Given this list of marker genes TRIM21, DNAJB12, CAMLG, OAZ2, RNF149, TGFB1I1, ADAMTS12, SOCS7, AGAP2, UBE2D2, DERL2, APP, MAP1A, FBXO4, KLHL2, ASB1, COP1, HYAL4, RSPRY1, WFS1, CDK2, SEC22B, DESI1, PRSS16, SF3B3, RNF7, DDIT3, SIRT1, AQP11, MIR128-1, RNF144A, SOX17, ATXN3L (ataxin 3 like), NRDC, WDR26, BCAS2, KCNE2, L3MBTL3, CHMP4A, SH3RF2, STX5, TLK2, ARIH1, UBR1 (ubiquitin protein ligase E3 component n-recognin 1), TMEM132A, PSMB6, USP25, ANAPC2, ERLEC1, PRAME, HGS, PSMB9, PRAMEF10 (PRAME family member 10), UBAP1, GZMA, VPS11, FURIN, XPO1, CAPN2, UBE2K, FBXW11, FBXL13, SERPINB12, IL33, RPS27A, PISD, PSMB4, NOTUM, PRAMEF22, RLIM, SPOPL, RNF139, HERC6, FLNA, ELANE, PAQR3, GRN, VPS36, PRAMEF5, ZFAND2B, CLN5, RNF20, EEF1A2, KLHL42, KEAP1, KLHL24, PSMD3, UFL1, PLAA, SNX33, UBE2S, UBE2C, ANKIB1, IRGQ, UBE3A, FBXL14, SLC6A7, FBXO38, TRIM38, CTSO, CUL1, VPS35, KLHL12, WNT1, TRIM72, PSME1, TMEM199, ANAPC7, CHMP6, STT3B, DCAF12, TIMP3, MTA1, PSMD14, ECRG4, TBX21, TRIM45, IVNS1ABP, KLHL23, USP14, HECTD3, SNX5, ADAM9, FBXO22, SKP1, SIAH3, LATS1, DDA1, AXIN2, CALR, CCDC47, CTSW, ZNF268, DENND3, CSNK2A3, GSK3B, RPS7, PIN1, AREL1, ASCC3, KLHL5, CELA1, TREM2, AMER1, TOLLIP, CDC26, TMUB2, ANXA2, RILP, FBXL20, F8A2, GIPC1, KLHL11, TMTC3, IL17RA, TP53INP2, KLHL35, PRAMEF19, KLF1, CELA2A, NOTCH1, CALR3 (calreticulin 3), MAGEF1, CUL4A, OGA, ISG15, PSMB2, FBXO24, BAG5, PSMA8, RNF41, CDC27, PSMA4, TBL1XR1, UBE3B (NCBI Gene Id 89910), ASB2, PSMD9, CTSH, NFE2L2, NEMF, KCTD5, STYX, OAZ3, RNF167, F8A3, ZFAND2A, TRIM24, PANO1, ANAPC4, UBQLN3, PTEN, ARMC8, UBE2L6, PSMA1, KLHL25, PPP1R11, FBXO8, SYVN1, ZNRF3, BTK, RNF175, GGA1, ADAM10, NQO1, FBXL5, TRAF2, PRAMEF26, DPP7, TMEM168, USP8, HECW1, HSP90AA1, PSMC6, NELL1, CASP8, UBE4A, PSMC2, NSFL1C, SMURF2, SIRT6, SPG11 (NCBI Gene Id 80208), RPL11, FBXL2, ZNRF4, TOPORS, CDC34, APC, CBLB, LYPLA2, PMAIP1, CUL7, BBS7, LGMN, RNF114, ATRAID, RNF13, DET1, RNF5, CANX, KBTBD7, PSME2, FBXL19, CPA1, LYPLA1, WAC, UBE2J1, TRIP4, LAPTM5, NDFIP1, PELI1, CRBN, PRAMEF33, UBE2I, RNF43, RNF144B, GABARAP, UBA7, IKBKG, CLOCK, FBXL15, CBLC, CHMP4BP1, KLHL3, BAG3, PJA1, F8A1, MTOR, CPA2 (carboxypeptidase A2), JKAMP (JNK1/MAPK8 associated membrane protein), ASB11, UBXN7, RC3H2, ENC1, TMEM259, TMX1, KLHL7, PRKN, CDC23, KBTBD12, RNF14, PSMA6, FBXO10, PCYOX1, APOC2, TF, RNF216, WWTR1, KCTD13, RHBDD1, TRIM26, TRIM3, CTSS, TSG101, GID8 (NCBI Gene Id 54994), UBR5, RNF6 (NCBI Gene Id 6049), SH3RF3, DNAJC3, RNF4, TRIM32, UBE2A, RELA, CAV3, PBK, NPLOC4, VPS37A, ANAPC10, TNFAIP3, SHARPIN, VHL, SOCS6, EPHA4, IER3, N4BP1, UBE2U, FBXL4, PCNP, DAB2IP, FBXO27, PABPN1L, RAB7A, UBA6, ANAPC5, VPS28, NEDD4L, RNF217, CD2AP, TBL1X, FMN2, IDE, ATP5IF1, ROCK1 (NCBI Gene Id 6093), NEDD8, SGSM3, PSMD11, SH3RF1, HECW2 (HECT, C2 and WW domain containing E3 ubiquitin protein ligase 2), PITHD1, KCTD2, NKD2, TRIM2, HSPA1B, EGFR, RNF34, TOM1L1, CHMP3, HYAL1, KLHL30, OTUD7A, UBE2L5, NOP53, CTRL, DAOA, MAD2L2, RPGR, CHFR, RCN3, MMP20, LPCAT1, UBQLNL, MGAT3, USP44, ARRDC1, ST14, PTPN3, ADAMTS4, HGSNAT, SNX3, RBX1 (ring-box 1), GPX1, PRAMEF13, WNT10B, CHMP1A, UBR7, VPS4A, AMN1, AGAP3, PACSIN3, CST3, RNF145, ADGRB1, FBXW7 (F-box and WD repeat domain containing 7), TRAF4, UBA1, CCAR1, SPSB1, MAN1C1, TRIB3, ANAPC1, CTSF, FMR1, SEL1L2, GZMB, CHEK2, HSPA1A, ANAPC13, USP17L6P, PPT1, CHMP2B, RCHY1, RNF40, SIAH1, RNF168, GCLC, APPBP2, HSPA5, TCIRG1, PDLIM2, MYCBP2, NGLY1, UBXN10, PKD1, CD81, BRSK2, CTNNB1, EXT1, TIPARP, CST7 (cystatin F), GNS, ZNF418, FEM1A, EGF, YOD1, PRAMEF1 (PRAME family member 1), ARRB2, ATG7, USP33, SIAH2, TRIM71, UFSP2, KBTBD2, HAMP, USP17L24, ARIH2, PSMF1, SGTA, PRKCG, HUWE1, PPP2R5C, UBQLN4, AZIN1, SMAD4, FBXL16, FBXO6, PSMD1 (proteasome 26S subunit, non-ATPase 1), ASB9, HM13, RNF126, ODC1, FBXL3, SNRNP70, UBD, RNFT1 (ring finger protein, transmembrane 1), NDUFA13, GSK3A, CDC20 (NCBI Gene Id 991), GPC3, PRAMEF15, CLU, PRAMEF8, EIF3H, MMP3, UBE2L3, LRRC75A, MVB12A, KAT5 (lysine acetyltransferase 5), RHBDD2 (NCBI Gene Id 57414), FBXL22, TNFRSF1B, PSMC5, TRAF7, ELOB, HSPA8, IL1B, CLPX, NHLRC3, ATE1, LAMP3, CBL, TMEM9, KCTD21, ANKZF1, EEF1A1, ABCA2, TAF1, CCIN, ADRM1, NUPR1, FBXO11, KLHL4, SPSB3, LRP1, TMEM129, FBXO31, SH3D19, MARCHF2, PTPN23, USP38, UBB, CENATAC, PRPF19, ZYG11B, HERC2, FBXO17, TNFSF12, SMURF1 (SMAD specific E3 ubiquitin protein ligase 1), MMP12, TRIM31, DCAF11, FBXL17, UFD1, ASB5, CSNK2A2, SNX1, HSP90AB1, CDK5RAP3, TSPAN15, MAD2L1, USP19, BAG2, UHRF1, OAZ1, HDAC6, SLC6A17, PSMD7, KLHL40, PARK7, UBR4, FBXW4, KLHL18, LDLR, CDC20B, TMEM67, GBA1 (glucosylceramidase beta 1), C4BPA, PSME3IP1, TRIM28, AMBP, FOXO1, RBBP6, CSNK1D, UBE2D1, HERC4, CPN1, GLMN, CMA1, CHMP4B, CUL2, UBXN11, UBR2, IDUA, WWP2, GRIN2C, MDM2, UBA52, LONRF2, SKP2, CSNK2B, ANAPC15, OTUD7B, SHH, AGTPBP1, LNX1, PABIR1, UMOD, MAN1B1, RNF130, SIRT2, STAM2, RNF146, ATF6, DERL3, KLHL38, CTSD, VCP, CCNF, PSMD6, KLHL22, RNF170, GUSB, CHMP5, FBXO9, SEM1, SPATA18, AP5Z1, VPS37B, PRAMEF17 (NCBI Gene Id 649345), CAV1, RDX, CUL5, BNIP3 (NCBI Gene Id 664), USP7, DMAC2, KLHL8, AFG2B, ABHD10, RNFT2, MIDN, TRIM40, KLHL29, PRAMEF4, APC2, KCTD10, DVL1, USP28, HERPUD1, USP13, TOR1A, TRIB1, ZDHHC2, MYLIP, UBXN2B, RNF187, FYN, AMFR, CYP51A1, EDEM2, KLHDC3, ERCC8, HERC3, TNF, ADAM8, RNF121, LONP1, CUL3 (NCBI Gene Id 8452), UBE2B, RNF11, TRIM9, CASP7, ARMC5, CDKN1B, UBE2J2, FAM83D, CLGN, TRPC4AP, PPP2CB, SLC17A9, UBXN1, PSMB7, PJA2, LIAT1, FBXL7, PSMD13, PCBP2, KCTD6, INS, VPS13A, TIMP2, RHOBTB3, MIB1, PYHIN1, PDCL3, PSMA3, LAMP2, ZRANB1, AURKA, ABHD17B, UBXN8, CLPP, DDI2, USP5, PSMB11, MTM1, FBXW5, DCST1, VIP, UBE3D, SORL1, CTSA (NCBI Gene Id 5476), CCDC115, LRIG2, PSME3, FBXO7, UBE2N, PSMB1, VPS4B, ADAMTS7, UBE2H (ubiquitin conjugating enzyme E2 H), HACE1, SNX12, UBE2Z, LTN1, CBFA2T3, MAN1A2, SMAD7, PRAMEF6, PCSK9, USP9X, HERC5, CTSC, PDCD6IP, FEM1C, HEXA, ATG5, PHF20L1, LRP2, UTP25, CDKN2A, RGMA, LONP2, PEX12, CEACAM1, RNF150, SMAD3, AZIN2, HSPBP1, ACR, OPHN1, UBXN6, DISC1, CNOT4, PSMB5, NUDT15, PSMA5, UBE3C, UBE2D4, KLHL28, ANAPC11, GAN, TRIM39, ATP13A2, UBE2E1, NR1D1, ELOC, MAGEA2B, IL10, RNF166, SGSH (N-sulfoglucosamine sulfohydrolase), MARCHF7, DEDD, TTC3, MARCHF6, RNF186, RNF8, PSMD8, PGPEP1, PSMD4, CLN8, PRICKLE1, SMARCC1, KLHL1, VPS37D, ANKRD9, RMND5A, ZNF598, BAG6, NDFIP2, PSMB8, RPL23, SUMO1, FBXO48, TMEM126A, BCAP31, XBP1, MAPK9, HPSE (NCBI Gene Id 10855), MDM4, UBR3, RNF133, ABHD17C, PCYOX1L, OSBPL7, CHMP1B, PIAS1, OS9, UBE2G2, MAGEA2 (NCBI Gene Id 83160), UBL7, NCCRP1, KLHL15, TMUB1 (NCBI Gene Id 83590), EDEM1, FAU, SDF2L1, HTRA2, RNF111, TAF9, TIMP1, VGLL4, FAF1, PRAMEF25, PSMA2, ARHGAP5-AS1, GPLD1, CTSZ, TRIM25, WNT5A, MAEA, DAB2, UBE2R2, BNIP3L, PML, DNAJC10, VPS37C, MSN (NCBI Gene Id 4478), DDB1, SUMO2, ADAMTS13, PSMD10, TPP1, MAGEC2 (NCBI Gene Id 51438), ADRA2A, RIPK1, KLHDC10 (NCBI Gene Id 23008), PRAMEF14, USE1, ZNRF1, APOB, CDH1, AGBL4, NEU2, HFE, MVB12B, UBAP1L, WDR77, STAM, UBC, UBE2D3, DTX3L, PRAMEF18, TMF1, OXA1L, PSMB10, BMAL1, RNF122, IPP, FAF2, RAB12, LAPTM4B (NCBI Gene Id 55353), RNF10, RACK1, FBXW8, DCAF13, PSMD2 (NCBI Gene Id 5708), PSMB3, FAM8A1, ALAD, TRIM58, NHLRC1, RGP1, CUL4B, DTX4, LRRK2, AMBRA1, MANBA, UBXN2A, ZSWIM8 (NCBI Gene Id 23053), ABHD17A, COMMD1, PRAMEF20, AKIRIN2, SOCS4, C4BPB, IFNG, SPSB2, DDI1, KBTBD6, UBQLN2 (NCBI Gene Id 29978), TRIM13, PRAMEF9, PTK2, SVIP, DERL1, SOCS5, OGT, NFE2L1, DNAJB2, CACUL1, RPL5, CSNK1A1, KLHL17, ECSCR, RAD23A, WDR81, CHMP2A, ARAF, PHB1, LRSAM1, KLHL20, YME1L1, PLK3, STUB1, SELENOS, KLHL10, RYBP, PRAMEF2, PRAMEF11, BAP1, ATM, CCDC22, NKD1, RHBDF1, SQSTM1, PSMC3, RNF180, EPG5, SNX9, RBCK1, NEURL3, PTK2B, WWP1, TMEM106B, RNF123, FBXO39, COPS3, HSP90B1, NEDD4, SENP1, RNF125, PINK1, PRKACA, ZER1, PSMD12, RNF215, DACT1, CDC16, ECPAS, UBL4A, ERLIN1, KLHL41, NEU4, SPSB4, CLN6, UCHL3, UBE2G1, SEL1L, TSPAN5, UBE2W, TRIB2 (NCBI Gene Id 28951), EZR, EPM2A, TIMP4 (TIMP metallopeptidase inhibitor 4), PLK2, SOCS2, GGA3, CHMP7, HIPK2, CREBRF, KCMF1, DDRGK1, ZNRF2, OMA1, NAGLU, CAPN3, AKT1, GFAP, MKRN2, PRAMEF27, FBXO46, SAYSD1, PRMT6, FBXL6, HEXB, QRICH2, SOX9 (NCBI Gene Id 6662), GID4, BRINP1, UBQLN1, RNF148, RNF185, APOE, TRIP12, KLHL6, PRAMEF7, WDR91, HMGCR, UBXN4, IRAK3, NTAN1 (N-terminal asparagine amidase), USP26, RNF213, CASP3, MFSD8, FBXO44, FOXF2, RFPL1 (ret finger protein like 1), PEX10, BFAR, ITCH, ARK2N, SUFU, SPOP, SH3BGRL, AUP1, PRAMEF12, VPS25, DNAJB9, FBXO2 (F-box protein 2), EFNA1, ARRB1, KBTBD8, IDS, DCAF1, RNF25, RNF128, ATXN3, FHIT, KCTD17, PLK1, SERPINE2, FBXL18, FAP, PSEN1, CUL9, ASCC2, FBXL12, BARD1, RHBDD3, BIRC2, CHMP4C, CSNK2A1, GLB1, CTSK, TNFAIP1, PSMA7, NUB1, EDEM3, RNF19B, FOXRED2, RNF103, FEM1B, PSMC4, IFT80 (intraflagellar transport 80), MMP14, CTSL, GRIN2A, ZMPSTE24, CSNK1E, CTSV, PSME4, RC3H1, RNF19A, TTC36, KLHDC2, BTRC (beta-transducin repeat containing E3 ubiquitin protein ligase), UCHL1, SNF8, TRIM67, GET4, MALT1, GABARAPL2, AXIN1, EGLN2 (egl-9 family hypoxia inducible factor 2), FZR1, FBXO21, HECTD1, DTL, UBAC2, MIR181B1, AFG1L, CLN3, KBTBD3, MAN1A1, DNAAF4, GNA12, KLHDC1, ERLIN2, CCAR2, FBXO45, PPP2R3A, NOS2, CEBPA, RNF26, LNPEP, IFI27, FBXO3, TSPAN17, UBE4B, MME, AFG3L2, CTSB, P2RX7, KLHL21, RNF115, RAD23B, ARK2C, GPC1 (NCBI Gene Id 2817), RIC1, KIF14, RFFL, SEC61B, PSMC1, MMP2, NSF, UCHL5 (ubiquitin C-terminal hydrolase L5), LIPA, ANAPC16, RMND5B, SNCA, here is a description of the gene set: The chemical reactions and pathways resulting in the breakdown of a protein by the destruction of the native, active configuration, with or without the hydrolysis of peptide bonds. Human Gene Set: GOBP_PROTEIN_CATABOLIC_PROCESS species: Homo sapiens